Given this list of marker genes Wdpcp, Dchs1, Rtkn, Lrch3, Anln, Septin9, here is a description of the gene set: A process that is carried out at the cellular level which results in the assembly, arrangement of constituent parts, or disassembly of cytoskeletal structures comprising septin complexes and their associated proteins. Mouse Gene Set: GOBP_SEPTIN_CYTOSKELETON_ORGANIZATION studied in species Mus musculus